The following is a description of a gene set: part of: RHO GTPase Effectors Reactome Pathway: RHO GTPases Activate WASPs and WAVEs species: Homo sapiens WASP and WAVE proteins belong to the Wiskott-Aldrich Syndrome protein family, with recessive mutations in the founding member WASP being responsible for the X-linked recessive immunodeficieny known as the Wiskott-Aldrich Syndrome. WASP proteins include WASP and WASL (N-WASP). WAVE proteins include WASF1 (WAVE1), WASF2 (WAVE2) and WASF3 (WAVE3). WASPs and WAVEs contain a VCA domain (consisting of WH2 and CA subdomains) at the C-terminus, responsible for binding to G-actin (WH2 subdomain) and the actin-associated ARP2/3 complex (CA subdomain). WASPs contain a WH1 (WASP homology 1) domain at the N-terminus, responsible for binding to WIPs (WASP-interacting proteins). A RHO GTPase binding domain (GBD) is located in the N-terminal half of WASPs and C-terminally located in WAVEs. RHO GTPases activate WASPs by disrupting the autoinhibitory interaction between the GBD and VCA domains, which allows WASPs to bind actin and the ARP2/3 complex and act as nucleation promoting factors in actin polymerization. WAVEs have the WAVE/SCAR homology domain (WHD/SHD) at the N-terminus, which binds ABI, NCKAP1, CYFIP2 and BRK1 to form the WAVE regulatory complex (WRC). Binding of the RAC1:GTP to the GBD of WAVEs most likely induces a conformational change in the WRC that allows activating phosphorylation of WAVEs by ABL1, thus enabling them to function as nucleation promoting factors in actin polymerization through binding G-actin and the ARP2/3 complex (Reviewed by Lane et al. 2014)., and this is the list of marker genes: WAS, WIPF1, ABI1, ARPC2, WIPF2, ARPC3, NCK1 (NCBI Gene Id 4690), WIPF3, PTK2, BTK, ABI2, NCKAP1, WASL, ACTR3, GRB2, ACTB, ARPC4, ABL1, WASF2, ARPC5, MAPK3, NCKIPSD, ACTR2, BRK1, BAIAP2, MAPK1, CYFIP1, WASF1, ARPC1A, RAC1, CDC42, CYFIP2, ARPC1B, NCKAP1L, WASF3, ACTG1